The following is a description of a gene set: Genes down-regulated in comparison of monocytes treated with 5000 ng/ml LPS (TLR4 agonist) versus those treated with 1 ng/ml LPS (TLR4 agonist). from publication Dower K, Ellis DK, Saraf K, Jelinsky SA, Lin LL (PMID 18292579) Human Gene Set: GSE9988_LPS_VS_LOW_LPS_MONOCYTE_DN studied in species Homo sapiens TREM-1 is an orphan immunoreceptor expressed on monocytes, macrophages, and neutrophils. TREM-1 associates with and signals via the adapter protein DAP12/TYROBP, which contains an immunoreceptor tyrosine-based activation motif (ITAM). TREM-1 activation by receptor cross-linking is pro-inflammatory, and can amplify cellular responses to Toll-like receptor (TLR) ligands such as bacterial lipopolysaccharide (LPS). To investigate the cellular consequences of TREM-1 activation, we have characterized global gene expression changes in human monocytes in response to TREM-1 cross-linking in comparison to and combined with LPS. Both TREM-1 activation and LPS up-regulate chemokines, cytokines, matrix metalloproteases, and PTGS/COX2, consistent with a core inflammatory response. However, other immunomodulatory factors are selectively induced, including SPP1 and CSF1 (i.e., M-CSF) by TREM-1 activation and IL-23 and CSF3 (i.e., G-CSF) by LPS. Additionally, cross-talk between TREM-1 activation and LPS occurs on multiple levels. While synergy in GM-CSF protein production is reflected in commensurate mRNA abundance, comparable synergy in IL-1b protein production is not. TREM-1 activation also attenuates the induction of some LPS target genes, including those that encode IL-12 cytokine family subunits. Whereas positive TREM-1 outputs are abolished by the PI3K inhibitor wortmannin, this attenuation is largely PI3K-independent. These experiments provide a detailed analysis of the cellular consequences of TREM-1 activation, and highlight some of the complexity in signal integration between ITAM- and TLR-mediated signaling., and this is the list of marker genes: GRTP1, MIR646HG, GOPC, TSPEAR, ISOC2 (NCBI Gene Id 79763), POM121, PAGR1, FBXL22, PAX9, ABHD8, TUBAL3, FAM187B, MUC1, LINC02347, TLE5, HEPACAM2, TMTC2, FAM182B, AKAIN1, TMEM254, PNKP, PPL, MUC7, ZBTB7B, STAG3L4, RIBC2, SLFN13, EPHA3, LINC01148, HS3ST1, TLCD5, SNTG1, ZYG11A, SPACA3, UGT2B4 (UDP glucuronosyltransferase family 2 member B4), OR2C3, ZNF23, SYCE2, PPARGC1B, KIF19, GGT6, STIL, SUN3, SLC30A10, LGR4, GSDMB, STAR, FRZB, ARL16, MORN3 (NCBI Gene Id 283385), LINC01549, POU3F3, MOBP, OR11A1, KRT79 (keratin 79), ARMH4, PEBP4, DISP2, PNPO, DAND5, ATAD3C, ST7, DDN, RNASEH1-DT (RNASEH1 divergent transcript), ASXL3, OR10H1, KRT20, SHCBP1, PRRT3, TRIL, ARL10, CFAP46, GPR85, VEPH1, TNNC2, BMP8B, CRB1, UNC5D, BPHL, PKP4-AS1, LGR5, RHOV, FGFR2, APBB2, COL18A1, LIN9, TMEM125, PREX1, ZNF439, LINC00261, ISLR, GAL3ST4, ZNF823, ANKS6, UQCC2, KRT16, PC, ENOX2, BAZ1B, CSTL1, ABCC6P1, TP53I3, BPIFB4, NOS3, PEX1, KCNK9, CDC6, NLGN4Y, LY6G6C, TRMT10B, SKAP1, CYP4F3, LINC00173, AGRN, CRCT1, SPZ1, FAM229A, CCDC59 (NCBI Gene Id 29080), RGS7BP, EMILIN1, PHB1P19, KRT27, ZNF740, GCGR, FAM3A, ACTL6B, GRB7, PAN2, POU2AF3, LINC00899, SEMA3D, PAX4, FOXF2, NUP62CL, IL9, SNHG4, AURKA, ELOVL3, SPC25, MPG, PCDH7, DLL1, TNKS1BP1, RASL10A, MYRFL, HASPIN, MYO3B, DKK3, NOL3, HSD17B7, OCEL1, TEX264, SOX2, CLTRN, GRHL3, RBM46, KIF15 (NCBI Gene Id 56992), CCDC7, HAO1, MYOCD, ENSG00000291149, CATSPERB, RGPD4-AS1, ENSG00000228021, GPR182, WNT2B, H1-3, CLEC3B, IGHV3OR16-13, SNRNP48, PPP6R2, CALCOCO1, LINC00943 (NCBI Gene Id 100507741), VCF2, BBOX1, CD22, MMRN2, NAP1L2, MED15P9, IL33, BCDIN3D-AS1, PARP10, PBX4, LINC01118, NPW